The following is a description of a gene set: Human Gene Set: GOBP_LYMPHOCYTE_ANERGY Any process contributing to lymphocyte anergy, a state of functional inactivation. studied in species Homo sapiens, and this is the list of marker genes: CBLB (NCBI Gene Id 868), NR5A2, ITCH, CD3E, LILRB4, CLC, HLA-B, PHLPP1, FOXP3